The following is a description of a gene set: species: Homo sapiens Binding to a caspase family protein. Human Gene Set: GOMF_CASPASE_BINDING, and this is the list of marker genes: NLRC4, BCL2L10, RIPK2, CARD18, CARD16, RIOK3, CARD17P, CTSG, FADD, NOL3, MAGEA3, BFAR, NLRP7